The following is a description of a gene set: Human Gene Set: HP_SPINAL_CORD_TUMOR A neoplasm affecting the spinal cord. Spinal cord tumor studied in species Homo sapiens, and this is the list of marker genes: LZTR1, COQ6, VHL, NF2, TRAPPC14, CREBBP, SMARCB1, VANGL1, ZFTA, CCND1, MNX1, RPL10, FLI1